The following is a description of a gene set: Human Gene Set: GSE26912_TUMORICIDAL_VS_CTRL_MACROPHAGE_DN The immune system can both promote and suppress cancer. Chronic inflammation and proinflammatory cytokines such as interleukin (IL)-1 and IL-6 are considered tumor-promoting. In contrast, the exact nature of protective antitumor immunity remains obscure. In this study, we have quantified locally secreted cytokines during primary immune responses against myeloma and B-cell lymphoma in mice. Strikingly, successful cancer immunosurveillance mediated by tumor-specific CD4+ T cells was consistently associated with elevated local levels of both proinflammatory (IL-1aplha, IL-1beta, and IL-6) and T helper 1 (Th1)-associated cytokines (interferon-alpha, IL-2, IL-12). Cancer eradication was achieved by a collaboration between tumor-specific Th1 cells and tumor-infiltrating, antigen-presenting macrophages. Th1 cells induced secretion of IL-1-beta and IL-6 by macrophages. Th1-derived interferon-gamma was shown to render macrophages directly cytotoxic to cancer cells, and to induce macrophages to secrete the angiostatic chemokines CXCL9/MIG and CXCL10/IP-10. Thus, inflammation, when driven by tumor-specific Th1 cells, may prevent rather than promote cancer. from publication Haabeth OA, Lorvik KB, Hammarström C, Donaldson IM, Haraldsen G, Bogen B, Corthay A (PMID 21407206) Genes down-regulated in macrophages: tumoricidal versus control. studied in species Homo sapiens, and this is the list of marker genes: C1QA, CKS2, PPP1R18, CRIP1, ANK1, MXD1, OLFM1, FCF1, CREB1, ACSS1, FH, CD52, TNFSF9, LY9, EXTL3, UBAC2, DPAGT1, GNG2 (NCBI Gene Id 54331), AURKB, CLDN1, PLP2, PADI1, ECE1, SEMA7A, CNOT3, PCNT, CYB5R1, RTN1, IGF2BP1, APOA2, ATP6V0A2, NEK4, UNC93B1 (unc-93 homolog B1, TLR signaling regulator), FGFR3, SLC12A3, STAT5A, DNPH1, GPD2, LPCAT1, ACSL5, BYSL, RS1, CSF1R, ZNF276, TXNDC17, PRR5, TRPC5, CD68, AMPD3, PNLIPRP1, CCR7, GLI1, RASA4, ADAM8, RPL6, BABAM2, IRF4, MATN1, CTSH, FNDC7, FNBP1 (formin binding protein 1), ELOA, RGS10, SLC52A2, RPS5, DBN1, PPFIA4, SMYD1, MYRF, KIT, COX14, SEMA5B, CSF2RA, FGF6, TMED8, CTSZ, MYG1, TYROBP, LSP1, MRPS21, NFKBIB, VNN2, TWF2, INPP5D, CD37 (NCBI Gene Id 951), KIF2C, ZFHX4, ST6GAL1, PIK3CD, STARD3, GPRASP1, SMARCD1, MRPL4, BATF3, ASCL1, PDYN, COL22A1, ANPEP, PTMS, ARHGAP39, NAA35, CNN2, CCR5, AURKA, ERO1B, PDLIM4, LRATD1, ADCY6, ESRRB, MYCL, PADI2, GSTO1, IL18, CLDN8, GDF3, TINF2, DERL2, HOXA7, CHRNE, CMTM7, RPLP1, RAD51, TBC1D1, GMFB, TMEM50B, PPP1R21, TBXAS1, GNB4, WDHD1, MFSD1, CHRND, IL18BP, ZNFX1, GYS1, MAGEL2, POU3F1, AUP1 (NCBI Gene Id 550), AP1G2 (NCBI Gene Id 8906), MACROH2A1, BLVRA, LAPTM5, NDE1, MYOG, INCENP, CLVS1, EXO1, RAD50, MTHFD2, CWC15, BCL2A1, CASP9, KDR, ITGB2, DHODH, SULF2, FXYD5, PSME1, SRSF9, RNF114, IGSF8, CDCA5, DAGLB, INPP5B, DCTPP1, ZCCHC3, TMED10, KLRD1, NEUROG1, PPARG, DNAJC5, RALA, KIF1A, CTSC, MXD3, PKM, GCLC, F9, GNRH1, TMEM43, PTGER2, EVL, HOXB5, NDRG4, PNMT, PCBD2, TNFRSF4, GNRHR, CRMP1, CDC25C, SPTLC2, BRK1, LGALS3, SCAMP2, CYBC1 (NCBI Gene Id 79415), HLA-DMA, GMIP, SHF, NUP62, TPPP3, TENT5C